Given this list of marker genes TRAPPC2L, RPS5, BLVRA, TTR, TAB3, PYGB, CFP, SUPV3L1, PIK3C3, GTF3C2, SARAF, POSTN, RPAP3, SLC10A6, OSMR, CWC15, SNHG6, CDC16, GRN, ANXA1, SST, RPS19, PNPT1, CXXC5, NCOA4, NUDT21, IFRD1, ACTR2, MYH9, TAF1C, EZR, EIF4A3, POLR1D, COL4A1, IPO4, DPP7, CAVIN2, SRSF2, RPL41, PSMD14, DHX40, AZI2, TOMM40, SPTBN1, TBC1D14, SNX14 (NCBI Gene Id 57231), CCDC86, RGS2, WDR20, FRG1, SLC25A15, CGGBP1, GNG12, CIP2A (cellular inhibitor of PP2A), RPL18, SAA1, ZCRB1, SSU72, MVP, MED28, CYB561, ARPC1B (actin related protein 2/3 complex subunit 1B), COL3A1, RO60, HEPH, ITIH3, IL1R1, NGDN, MPEG1, S100A6, RRBP1, TTC14, RANBP1, TAB2, CD47, SPTLC2, IL6R, MAP4K4, B4GALNT1, TIPARP, PPA1, TYROBP, PUF60, PRLR, PSENEN, ETNK1, SOD3, SEBOX (SEBOX homeobox), PRDM1, RRP7A, H3-4, TMEM176B, UNC45A, DDIT3, F11R (F11 receptor), PLAC8, SEMA6B, SSB, CAMLG, RPL34, NID1, ING1, TMX1, ARHGAP1, APP, MLX (NCBI Gene Id 6945), WWP2, ARMC10, LCN2, VTN (NCBI Gene Id 7448), MARCKS, DEGS1 (delta 4-desaturase, sphingolipid 1), SRSF9, RSRC2, FAM13B, SRSF11, RAN, CCDC28B, PPM1G, GAS6, CHD4, RPL23A, PLA2G7, PTPRB, CPNE3, FBN1, SPIN1, MRPL35, C5orf15, SMC3, SNRPC, ZSCAN26, KMT2E, RTN4, ATF4, TRIR, ATOX1, LSG1, GBA1 (glucosylceramidase beta 1), CFI, WIPF1, ATP11A, SURF6, AMBP, MAP7D1 (NCBI Gene Id 55700), HPX, WSB1 (WD repeat and SOCS box containing 1), ABRACL, TPP1, KIF22, THPO, PLK1, MTPN, KCNJ8, KIF1C, TCIRG1, PTTG1, HNRNPD (NCBI Gene Id 548), SLC25A4, GNAT1, APOC2, RHOD, ITIH1, COL4A2, VPS28, RPS25, NXF1, GALNT2, RAMP1, A2M, RBM10, ADCK1, ITGB1, CARS1, KIF2A, ZDHHC16, FOXK2, DCTN3, KRT18, PAX6, TUBB6, EMC10, CHD8, ATP5IF1, NELFE, COL14A1, FNBP1, NID2, APOM, SMN1, SLC39A1, RNF13, DYNC1I2, HIP1R, CCDC80, PISD, GNG10, BAX, ABCA1 (NCBI Gene Id 8371), MRPS26, here is a description of the gene set: Human Gene Set: GSE37301_GRANULOCYTE_MONOCYTE_PROGENITOR_VS_RAG2_KO_NK_CELL_DN from publication Ramirez K, Chandler KJ, Spaulding C, Zandi S, Sigvardsson M, Graves BJ, Kee BL (PMID 22608498) species: Homo sapiens Expression profiling of Rag2-deficient Ets1++ and Rag2-deficient Ets1-- mature NK cells and WT bone marrow progenitors, WT T cells, and WT Pro B cells Genes down-regulated in granulocyte-monocyte progenitor versus RAG2 knockout NK cells.